The following is a description of a gene set: Reactome Pathway: Metabolism of RNA studied in species Homo sapiens This superpathway encompasses the processes by which RNA transcription products are further modified covalently and non-covalently to yield their mature forms, and the regulation of these processes. Annotated pathways include ones for capping, splicing, and 3'-cleavage and polyadenylation to yield mature mRNA molecules that are exported from the nucleus. mRNA editing and nonsense-mediated decay are also annotated. Processes leading to mRNA breakdown are described: deadenylation-dependent mRNA decay, microRNA-mediated RNA cleavage, and regulation of mRNA stability by proteins that bind AU-rich elements.psnRNP assembly is also annotated here.<p>The aminoacylation of mature tRNAs is annotated in the "Metabolism of proteins" superpathway, as a part of "Translation"., and this is the list of marker genes: POM121C, NUP155, SEM1, PABPC1, DDX46, HSD17B10, EXOSC8, PRKRIP1, SNRNP40, CPSF7, TRMT9B (NCBI Gene Id 57604), TGS1, MT-RNR1 (mitochondrially encoded 12S rRNA), YBX1, KRR1, CNOT11, RPS16, PPP1R8, MRM1, NUP210 (NCBI Gene Id 79985), CWC25 (CWC25 spliceosome associated protein homolog), MT-TS2 (NCBI Gene Id 8020), RCL1, RPS4X, WDR33, SARNP, UPF1, NUDT21, MT-TM, TRMT61A, QNG1, NUP188, PSMC4, ZC3H4, CRNKL1, RPL32, TBRG4, FASTK, SRSF3 (NCBI Gene Id 6428), FTSJ3, RPPH1, WTAP, TEX10, TSEN2 (NCBI Gene Id 80756), ELAC2, YJU2, MT-ND6, CSTF3 (NCBI Gene Id 1479), RANBP2, RPS14, EIF4A2, DNAJC8, WDR75, RPS15, SNRPB2, CPSF3, CCAR1, RPS17, APOBEC2, DDX1, GTF2H2, RPS27L, PSMB7, PAN3, FAU, IGF2BP2, DHX35, RPL4, NAT10, CDKAL1, NUP43, NOL9, DXO, TBL3, NXT1 (nuclear transport factor 2 like export factor 1), A1CF, UBC, PUS1, THOC6, RPL26L1, RPS21, DCPS (decapping enzyme, scavenger), ACIN1, CNOT7, WDR3, EIF4A3, RNU4ATAC, PSMD2, RIOK2, CNOT10, PAPOLA, GTF2F1, TRMT10C, THOC3, YRDC, SRSF10, 18S rRNA, ADAT1, CASC3, ZC3H11A, YWHAB, GPRC5A, METTL1, EXOSC10, PNPT1, CPSF4, SRSF12, TENT4A, MT-RNR2, POP7, TSR1, RPL37A, PUF60 (poly(U) binding splicing factor 60), FYTTD1, MFAP1, GRSF1, SNRPF, WDR77, TNFSF13, MT-TV, GEMIN7, GTF2F2, RPS6, RPL8, PRPF18, CWF19L2, MT-TR, CNOT6, SMG5, CNOT9, SNRPN, SNORD3A, NKAP, EMG1, PQBP1, RBMX2, RPS26, EIF4E, SMG8, POP4, PPP2R1A, TUT4, SF1, PES1, DDX23, POP1, DDX39A, NUP37, PSMD3, DDX39B, PCBP1, HNRNPH1, WDR46, SNIP1, UTP15, SET, RPS23 (NCBI Gene Id 6228), PSMC5, RPL3L, NUP35, TRMT13, RBM8A, GTF2H3, TRMT1, BMS1, SMU1, MNAT1, TSR3, POLR2K, PSMA5, DCP1A, RNU11, GTF2H5, ACTB, CSTF1, SF3B6, PSMD7 (NCBI Gene Id 5713), MTREX, NOL11, PARN, FIP1L1, MT-TK, POLR2G, GEMIN4, ZC3H18, RPP21, SNRPE, CSTF2T, POLDIP3, FASTKD5, MT-TS1, TSEN54, PABPN1, NUP42, TRMT11 (tRNA methyltransferase 11 homolog), MT-TI, TUT1, PCBP2, FAM50A, C9orf78, RPL27, GTF2H1, TRA2B, HNRNPU, NUP50 (NCBI Gene Id 26132), PAIP1, RBMX (RNA binding motif protein X-linked), QTRT2, SMG1, RCC1L, HNRNPL, SART1, MT-TD (mitochondrially encoded tRNA-Asp (GAU/C)), RPS28, LUC7L3, MPHOSPH10, CSTF2, CNOT3, XPOT, DDX42, MT-TC, RIOK3, PSMB6, PRPF19, QTRT1, TFB1M, MT-TY, CLNS1A, RPS4Y2, PSMD11, EFTUD2, ZMAT5, UPF2, CNOT4, SRSF8, BYSL (NCBI Gene Id 705), NUP153, 5S rRNA, RPP25, TRMT61B, MT-ATP8, PSMB4, RPL39, CPSF6, NUP107, RPL13A, PPIH, RPL28, RPL22L1, BOP1, TYW1, HEATR1, PUS7, SDE2, WBP4, RPS18, FUS, PSMD12, OSGEP, EBNA1BP2, PRKCA, UTP11, UTP25 (UTP25 small subunit processome component), USP39, RPL31, CD44, RPL10 (NCBI Gene Id 88324), MT-CO1, LRPPRC, LUZP4, PPIE, TNPO1 (transportin 1), CNOT1, NUP98, TUT7, SNRPD1, TRDMT1, POLR2L, RPLP1, RPS29, NT5C3B, MT-ND3, PSMD1, SF3B3, HNRNPM, CNOT6L, PSMD14, RNMT, RNPS1, ZCRB1, ANP32A, LENG1, RPS11, GLE1, RPL11, RRP1, NUP214, WDR70, SAP18, MT-TH (NCBI Gene Id 4564), SLIRP, LAGE3, CCDC12, PSMA6, CSNK1D, RPL9, MT-TL1, LSM8, LSM5, NCBP2, CHERP, TNKS1BP1, PAPOLG, TRMT112, RBM5, SMG6, MT-TL2, NSUN2, UPF3A, RIOK1, PPP2CA, EXOSC4, SNUPN, TPR, PSMB3, RPS3, RPP38, ADAR, POM121, U2AF1, DDX41, DUS2, POP5, CNOT8, ISG20L2, POLR2E, NOP14, RBM39, STEEP1, THADA, EXOSC5 (exosome component 5), POLR2B, PSMA2, DHX9, SF3A3, EXOSC2, POLR2H, CNOT2, RPL5, RBM25, FAM98B (NCBI Gene Id 283742), PRMT5, NUP205, ZCCHC7, RNPC3, LSM6 (NCBI Gene Id 730962), TXNL4A, ADAT3, RPL35A, MT-ND1, AQR, RPP30, SNRPA1, MT-CO3, DHX15, TSEN34 (NCBI Gene Id 79042), RPL10L, HNRNPA2B1, RPS19, GAR1, ZNF830, PRPF38A, SNRPB, SRSF11, IGF2BP1, LSM3, TRMT44, PSMA3, MTO1, MT-TW, DHX16 (NCBI Gene Id 8449), RBM7, MRM3, FTSJ1, GSPT2, PWP2, SNRNP25, MT-TT, IGF2, MTERF4, FBL, NUP62, MT-TE, RPL18A, U2AF2 (U2 small nuclear RNA auxiliary factor 2), YTHDC1, MT-TN, PPIL2, NXF2, NOP58, SRSF1, HSPA1A, TPRKB (NCBI Gene Id 51002), HNRNPD, SRRM1, RPL38, SF3B1, PDCD7, SKIC3, DDX20 (NCBI Gene Id 51452), U2AF1L4, OSGEPL1, PRPF6, GEMIN6, SLU7, TFIP11, PSMA1, EIF4B, PTBP1, EPRS1, ERI1, SNRPG, SF3B2, MAGOHB (mago homolog B, exon junction complex subunit), TRMT5, APOBEC3C, RPL27A, RPLP0, PCF11, DIS3, PRCC, PSMD6, SNRNP200, MT-ATP6, MPHOSPH6, U2SURP, THOC2, ADARB1, SNRNP70, SF3B5, DKC1, RPL18, XPO1, PPIL1, GPKOW, RPS25, TRIT1, NSUN4, RNF113A, RPS27A, NOC4L, RPL24, RPL37, MT-TA, CDC40, THOC5, PRPF4, RBBP6, GSPT1, GEMIN5, UTP14C, SF3A1, SNRPC, CCNH, DDX52, ZCCHC8, CTNNBL1, TP53RK, TENT4B, WDR18, POLR2A, RPL26, MT-ND4, UBA52, MRM2, RPP14, PPP1CA, MAGOH, SKIC2, RRP7A, CSNK1E, 5.8S rRNA, TCERG1 (transcription elongation regulator 1), ZRSR2, RBM10, PSMD13, APOBEC1, TYW5, RPS2, NCL, HBS1L, RPSA, IMP4, DHX38, TRMU, POLR2C, GEMIN8, RPS27, THOC7, SRSF4, PSMB1, DHX8 (NCBI Gene Id 1659), RNGTT, MT-CO2, SEH1L, PSMC6, MAPK11, SMG7, NHP2, SNW1, SNU13, CTU2, PPWD1, DCAF13, WDR43, RPS15A, GON7, SRRT, BUD23, PPP1CB, APOBEC4, GTPBP3, DDX6, RPL3, ZC3H3, BUD13, NOL6, LSM1, RPL34, NUP93, ELAVL1, RPS20, CWC22, LCMT2, AAAS, SF3A2, UTP6, CPSF1 (NCBI Gene Id 29894), CLP1, GCFC2, NGRN, RPL6, FASTKD2, RPS8, APOBEC3A, PUS3, ADAT2, MT-TG, RPL13, SNRPD3, BCAS2, PRPF3, NUP85, DHX37, MAPKAPK2, APOBEC3H, NCBP1, TYW3, EIF4A1, RPL14, CTU1, RPL35, PPP1R10, RAN, ADRM1, SF3B4, YWHAZ, MT-TP (mitochondrially encoded tRNA-Pro (CCN)), RPP40, RRP36, RPS9, EXOSC7, KHSRP, UTP3, NUP54, SYMPK, PNO1, MYC, CHTOP, TRUB2, HTATSF1, SEC13, RAE1, SNRNP35, RTCB, RPLP2, SUGP1, H19, XAB2, DDX21, SNRPA, RPUSD4, NIP7, HSPA8, DCP1B, RRP9, 28S rRNA, IMP3, FCF1, RPL29, CWC15, SRSF5, SMNDC1, PNRC2, NUP88, CDK7, SMN1, METTL14, GEMIN2, SLBP (stem-loop histone mRNA binding protein), LSM7, HNRNPA1, RTRAF, ZFP36L1, PPP2R2A, SMG9, PSMD8, AKT1 (NCBI Gene Id 207), NXF1, THG1L, POLR2J, PSMB2, WDR12, MT-ND5, IK, GNL3, PHF5A, TSEN15, RPL23, RPL7A, NOP56, UTP20, EDC3, LAS1L, UBL5, RPS4Y1, YTHDC2, RPS10, MTPAP, TRNT1, RNA45S5, XRN2, NUP160, RPL17, NSUN6, EXOSC1, CWC27 (CWC27 spliceosome associated cyclophilin), RPL36, EXOSC9, SENP3, TYW2, WDR4, PPIL4, PRKCD, NUP58, PPIG, DDX5 (DEAD-box helicase 5), CPSF2, ALYREF, UTP4, SRSF9, PATL1, RPL30, PAN2, RPS24, RPUSD3, NOP10, HSPB1, NOB1, NOL12, LSM10, RPL10A, SRSF2, ERCC3, RPS12, RPL23A, rep, IGF2BP3, MT-TF, EXOSC6, MT-ND4L, RBM22, THOC1, LSM11, TRMT10A, RPL22, MT-TQ (mitochondrially encoded tRNA-Gln (CAA/G)), C1D, PRORP, PSMA7, CDC5L, EDC4, PRPF8, RPS3A, ENPP2, ERCC2, RBM17, FAM32A, PRPF40A, WBP11 (WW domain binding protein 11), PELP1, GPATCH1, SNRPD2, RPL7, METTL3, MT-CYB, PPIL3, POLR2I, ZFC3H1, HNRNPF (heterogeneous nuclear ribonucleoprotein F), NSRP1, PRPF31, LSM2, HNRNPC, ETF1, SNRNP27, EXOSC3, PLRG1, PSMC1, HNRNPK, MT-ND2, RPL12, NUP133, PRP4K, ZBTB8OS, RBM26, SYF2, NOP2, POLR2F, RPL19, RPS13, APOBEC3B, RNU12, C2orf49, POLR2D, THUMPD1, LTV1, ALKBH8, WDR36, ZNF473, DDX47, UTP14A, DCP2, PSMC2, CACTIN, REXO2, RBM27, RPL36AL, ISY1, HNRNPA3, ZFP36, UTP18 (UTP18 small subunit processome component), PDCD11, NDC1, XRN1, WDR82, GTF2H4, RBM28, RPL39L, SKIC8, PSMA4 (NCBI Gene Id 5685), RPS7, RPL36A, MTERF3, SUPT5H, SRSF7, LSM4, SUPV3L1, DDX49 (DEAD-box helicase 49), PSMC3, PNN, RPL21, RPL15, UBB (ubiquitin B), BUD31, ZMAT2, TRMT6, HNRNPH2, SNRNP48, HNRNPR (NCBI Gene Id 10236), SRSF6, MAPK14, RPL41, PHAX, RPS5, SRRM2, PSMB5, RBM42, EIF4G1, DIMT1, URM1, UPF3B